Given this list of marker genes AIP, ARNT, AHR, PTGES3, HSP90AB1, AHRR, ARNT2, here is a description of the gene set: Reactome Pathway: Aryl hydrocarbon receptor signalling part of: Phase I - Functionalization of compounds studied in species Homo sapiens The aryl hydrocarbon receptor (AHR) is a ligand-activated transcription factor that belongs to the basic helix-loop-helix/PER-ARNT-SIM family of DNA binding proteins and controls the expression of a diverse set of genes. Two major types of environmental compounds can activate AHR signaling: halogenated aromatic hydrocarbons such as 2,3,7,8-tetrachlorodibenzo-p-dioxin (TCDD) and polycyclic aromatic hydrocarbons (PAH) such as benzo(a)pyrene. Unliganded AHR forms a complex in the cytosol with two copies of 90kD heat shock protein (HSP90AB1), one X-associated protein (AIP), and one p23 molecular chaperone protein (PTGES3). After ligand binding and activation, the AHR complex translocates to the nucleus, disassociates from the chaperone subunits, dimerises with the aryl hydrocarbon receptor nuclear translocator (ARNT) and transactivates target genes via binding to xenobiotic response elements (XREs) in their promoter regions. AHR targets genes of Phase I and Phase II metabolism, such as cytochrome P450 1A1 (CYP1A1), cytochorme P450 1B1 (CYP1B1), NAD(P)H:quinone oxidoreductase I (NQO1) and aldehyde dehydrogenase 3 (ALHD3A1). This is thought to be an organism's response to foreign chemical exposure and normally, foreign chemicals are made less reactive by the induction and therefore increased activity of these enzymes.<br><br>AHR itself is regulated by the aryl hydrocarbon receptor repressor (AHRR, aka BHLHE77, KIAA1234), an evolutionarily conserved bHLH-PAS protein that inhibits both xenobiotic-induced and constitutively active AHR transcriptional activity in many species. AHRR resides predominantly in the nuclear compartment where it competes with AHR for binding to ARNT. As a result, there is competition between AHR:ARNT and AHRR:ARNT complexes for binding to XREs in target genes and AHRR can repress the transcription activity of AHR.